The following is a description of a gene set: Genes predicted to be targets of miRBase v22 microRNA hsa-miR-6822-3p in miRDB v6.0 with MirTarget v4 prediction scores > 80 (high confidence targets). species: Homo sapiens Human Gene Set: MIR6822_3P from publication Chen Y, Wang X (PMID 31504780), and this is the list of marker genes: DIXDC1, SLC31A1 (solute carrier family 31 member 1), CLASP1 (NCBI Gene Id 23332), QTRT2, MAGED1, CASP2, GDAP1, ZDHHC23, PDS5A, AKAP12, SPTSSA, E2F4, GOLGA6L10, PDXK, KCNJ3, TWNK, RAD51D, MTUS2, FRA10AC1, ADAM12, G6PC2 (NCBI Gene Id 57818), CDK17, ZCWPW2, LSM12, SLC5A5, SLC35A2, WSB1, ITPR1, GPC6, FBXW4, SMC5, IRAK4, DERL2, KLK9, SRSF11, MAP2, CNTNAP2 (contactin associated protein 2), SERPINB1, BIRC6, CACNA1D, ANKRD29, ZSWIM2, OXSR1, MAGI1, KDM5B, SDC2, SLC4A4, ZSWIM6, BCL2L2, ZNF491, MICAL2, KCTD7, TSGA10, ADCY1